The following is a description of a gene set: Human Gene Set: HP_INABILITY_TO_WALK Inability to walk studied in species Homo sapiens Incapability to ambulate., and this is the list of marker genes: SLC38A3, NFU1, PEX1, APTX, TRIM2, GRIA4, SNX14, STXBP1, DNAJB6 (DnaJ heat shock protein family (Hsp40) member B6), TIMM8A, VPS51 (NCBI Gene Id 739), ASXL1, GABRA2, EMD, HMGCR, DHX30, DOHH, STAG2, TOR1A, PLP1, PRUNE1, KCNQ2, ASAH1, SDHA, PIGP, AP4B1, RRM2B, PIGS, UCHL1, HNRNPH1, HNRNPA2B1, LNPK, STRADA, DARS2, CDON, CLDN11, ADAM22, DYM, PODXL, ZNF526, GABBR2, PURA, GNAO1, NEFL, HNRNPA1, UBE4A, GOSR2, BVES, CTBP1, PSMC1, VAPB, HINT1, LMX1B, TBC1D24 (NCBI Gene Id 57465), MCM3AP, SDHD, SMN1, SMN2, COQ2, SMS, EXOSC5, TNPO2, VAC14, POMT1 (protein O-mannosyltransferase 1), SGCG, RNU4-2, UBTF, PANK2, MARS2, ST3GAL3, FGFR1, GRIN1, PPP1R21, EIF2B5, MPV17, TREX1, DSTYK, KCNJ10, GABRB2 (gamma-aminobutyric acid type A receptor subunit beta2), EIF2AK2, PRKN, TSEN15, SLC25A22, LYRM7, PLA2G6, MAPK8IP3, PGAP2, NEU1, POLR3A, MFSD2A, SLC16A2, SCN3A, GLRX5, MPZ, MAFB, FCSK, SCN1A, CTNNA2, GPAA1 (NCBI Gene Id 8733), GSX2, CLN8, POLR1A, P4HTM, LMNA, TMEM107, ATL3, SLC19A3, SLC12A5, RRM1, FGF12, SCN2A (NCBI Gene Id 94312), PDHA1, ATP8A2, GEMIN5, PIEZO2, GMPPB, TBCD, OPTN, REPS1, SLC12A6, TMEM231, GLE1, NEUROD2, ARL6IP1, AP4S1, HYCC1, MFF, PEX16, RHOBTB2, GCDH, DOCK7, GLI2 (NCBI Gene Id 50806), MEF2C, GRIK2, ATP6V1A, CACNA1I, VPS13A, GIPC1, SPTLC2 (NCBI Gene Id 9517), DNAJC6, HK1, CRAT, SYNJ1, TRAPPC2L, ASPA, GRM1, LRP5, LRPPRC, MAG, TGIF1, MT-ATP6, NDUFA6, SLC1A4, ZC4H2, ITPR1, ALS2, TBC1D23, TRAPPC11, NKX6-2, MYOT, POGLUT1, CACNA2D2, OTUD7A, CHCHD10, LYST, NTNG1, UQCRQ, GNPTAB, GNB1, MRPS34, STAC3 (NCBI Gene Id 246329), NUP54, VAMP2, DYNC1I2, TUBB3, VPS41, CDKL5, NDRG1, DNM2, PRX, CAPRIN1, NOTCH2NLC, PMP22, RPL10, WDR45B, SMPD1 (sphingomyelin phosphodiesterase 1), SPTLC1, FGF8, ATP6AP2 (NCBI Gene Id 95880), CLTC, CRIPTO, AIMP2, TFG, TK2, CLN3, FXN, SEC31A, ADAR, CLN5, CNPY3, VPS13C, NODAL, VCP, FA2H, LONP1, SLC6A17, RILPL1, CHRND, NTRK2, CELF2, NTNG2, VPS33A, MT-TE, CAPN1, MAST1, SPG11, SGCB, MTM1, PSMB1, DMD, EXT2, GGPS1, INTS8, CACNA1A, CRELD1, FLNC, PLEC, MECP2, COQ4, SCO2, CAMK2B, PPIB, ACTB, FUS (NCBI Gene Id 406232), TWNK, SDHAF1, ADSL, KLHL9, CAMK2A, NHLRC1 (NHL repeat containing E3 ubiquitin protein ligase 1), SLC33A1, SNCA, SBF1, AP4E1, ALDH18A1, PIGA (phosphatidylinositol glycan anchor biosynthesis class A), COPB1, PPP2R1A, TGM6, HTT, DNM1L, GRIA2, SHH, PYCR2, SELENON, POT1, SH3TC2, CACNA1B, HNRNPK, TELO2, EXTL3, LAMA2, ERLIN2, UNC80, PTCH1, TRPM3, CHKA, HMBS, SLC17A5, SPTAN1, KIF1A, MTMR14, AFG2A, FARS2, GFM2, KLC2, PEX11B, ESAM, SUCLA2, IRF2BPL, CACNA1G, PMPCB, ZEB2, NGLY1, GALC, HACE1, CRPPA, DNM1, ASXL3, MECR, NUP62, FAR1 (fatty acyl-CoA reductase 1), LRP12, AGTPBP1, MED25, JAG2, ABCD1, POLR3B, MTRFR, ADSS1, MSTO1, DISP1, EPRS1, EIF2S3, SLC39A14, SMC1A, SNUPN, TNR, HSD17B10, TRIM32, ABHD16A, SDHB, MORC2, MAPT, WARS1, GEMIN4, SATB1, LETM1, PI4K2A, OTUD6B, ZIC2, DLL1, MDH2, EIF2B3, MBOAT7, CACNA1E, DYSF, GAS1, TBC1D20, LARGE1, GPRC5B, TBR1, SERAC1, SYNE1, ATL1, FKRP, ERBB4, MAGEL2, PLCH1, NEB, BCAS3, ATN1, RAB18, GOT2, VPS16, SLC25A4, MYH7, INTS1, FHL1, SLC39A8, DCPS, CLIC2, VARS1, PLCB1, DES, SLC35A2, TRIP4, SLC2A1, PSAP, LDB3, GTPBP2, SELENOI, DPAGT1, GDAP1, SLC9A6, SYT1, ATAD3A, SIGMAR1, KCNT1, FOXH1, SIX3, POMT2, TBCK, PGAP3, SLC1A2, SBF2, EPM2A, MFN2, FOXRED1, ATM, STIL, SLC2A3, CPLX1, C19orf12, ACTL6B, COPB2, SAMD9L, RNASEH1, DPYD